The following is a description of a gene set: studied in species Homo sapiens Human Gene Set: GOBP_DNA_CONFORMATION_CHANGE A cellular process that results in a change in the spatial configuration of a DNA molecule. A conformation change can bend DNA, or alter the, twist, writhe, or linking number of a DNA molecule., and this is the list of marker genes: TDRD3, ERCC3, HNRNPA2B1, TOP2B, HMGB1, HMGB2, DNA2, MTERF1, TOP2A, HHEX, TOP3B, BLM, TOP3A, HMGB3, TOP1, WRN, TOP1MT, ABL1